Given this list of marker genes TRAPPC13, CSNK1D, TRAPPC1, TRAPPC2, SAR1B, TRAPPC3, PDCD6, TRAPPC2L, AP3B2, TRAPPC2B, TMED2, AP3M2 (adaptor related protein complex 3 subunit mu 2), TRAPPC6B, KLHL12, TRAPPC10, PREB, PEF1, TRAPPC11, CUL3, TRAPPC4, MAPK15, TRAPPC6A, TRAPPC5, TRAPPC9, AP3S1, AP3D1, TMED10, SEC16A, TRAPPC8, SAR1A, PPP6C, TFG, TRAPPC12 (trafficking protein particle complex subunit 12), ARFGAP3, GBF1, TMED9 (transmembrane p24 trafficking protein 9), AP3S2, ARFGAP2, here is a description of the gene set: A protein coat is added to the vesicle to form the proper shape of the vesicle and to target the vesicle for transport to its destination. species: Homo sapiens Human Gene Set: GOBP_VESICLE_COATING